Given this list of marker genes Isl1, Wfs1, Neurod1, Spop, Srsf6, Capn10, Ngf, Ager, Hdac3, Atg7, Pdx1, Tcf7l2, Eif2s1 (eukaryotic translation initiation factor 2, subunit 1 alpha), Cast, here is a description of the gene set: Any process that modulates the frequency, rate or extent of type B pancreatic cell apoptotic process. Mouse Gene Set: GOBP_REGULATION_OF_TYPE_B_PANCREATIC_CELL_APOPTOTIC_PROCESS studied in species Mus musculus